Given this list of marker genes CBLB, YBX3, ELOC, PID1, RORA, MTHFD2, SQOR, GLCE, REV3L, HSPB6, RBMS3, COL1A1, LAMA4, PDGFRL, SRM, CP, PTMA, TMEM70, ELL2, NASP, GEM, YWHAB, SPTBN1, LAPTM4A, LARP6, TGFBI, OTULINL, NTRK3, C7, PLSCR1, PNRC1, PPIB, TFPI, PLXDC1, AKR1C2, PDPN, TOP1, SOX4, RHOBTB3, IFNAR1, UGP2, ABCA9, RBM17, CALD1, SSR3, MYOC, CALCRL, P4HB, BMP1, SEC61B, FMO3, APOL4, PFKFB3 (6-phosphofructo-2-kinase/fructose-2,6-biphosphatase 3), SCARA5, LPIN1, SAT1, RBMS1, TSC22D1, AKR1C1, C1RL (complement C1r subcomponent like), PITPNC1, MXRA8, GMDS, SELENOM, BGN, IFNGR2, LARP4, GGT5, CNN3, CHEK2, NFIA, CREM, AK3, ITM2B, NR2F2, SLC39A14, IL15RA, LTBP4, PTP4A2, FILIP1L, CTTNBP2, LIMA1, SERPINF1, CCDC71L, S100A11 (NCBI Gene Id 6282), here is a description of the gene set: Human Gene Set: GAUTAM_EYE_IRIS_CILIARY_BODY_MGP_HIGH_FIBROBLASTS Occular cell types curated from Gautam and Hamashima et al. Multi-species single-cell transcriptomic analysis of ocular compartment regulons from publication Gautam P, Hamashima K, Chen Y, Zeng Y, Makovoz B, Parikh BH, Lee HY, Lau KA, Su X, Wong RCB, Chan WK, Li H, Blenkinsop TA, Loh YH (PMID 34584087) studied in species Homo sapiens